Given this list of marker genes HEXA, here is a description of the gene set: Beta-hexosaminidase (HEX) cleaves the terminal N-acetyl galactosamine (GalNAc) from glycosaminoglycans (GAGs) and any other molecules containing a terminal GalNAc. There are two forms of HEX; HEXA and B. The A form is a trimer of the subunits alpha, beta A and beta B. The B form is a tetramer of 2 beta A and 2 beta B subunits. Defects in the two subunits cause lysosomal storage diseases marked by the accumulation of GM2 gangliosides in neuronal cells. Defects in the alpha subunits are the cause of GM2-gangliosidosis type 1 (GM2G1) (MIM:272800), also known as Tay-Sachs disease (Okada & O'Brien 1969, Nakano et al. 1988). Classical Tay-Sachs disease is characterised by infant-onset neurodegeneration followed by paralysis, dementia and blindness, Death occurs by the age of 2 or 3. The two other forms of Tay-Sachs disease, juvenile- and adult-onset, are less commom and severe than the infant-onset form. Reactome Pathway: Defective HEXA causes GM2G1 (Hyaluronan metabolism) part of: Diseases associated with glycosaminoglycan metabolism studied in species Homo sapiens